Given this list of marker genes PTGES2, CEBPB, PTPN11, MTOR, CAMK2D, CAMK2G, CAMK2A, JAK1, RAPGEF1, PRKCD, CRKL, SMAD7, PIK3CA, STAT1, IL1B, IFNG, IFNGR1, RAP1A, RAP1B, CBL, MAPK1, IRF9, CREBBP, MAPK3 (NCBI Gene Id 5595), SOCS1, EP300, IRF1, MAP3K11, PIK3R1, STAT3, MAP2K1, AKT1, CAMK2B, PTPN2, PIAS1, CASP1, PIAS4, MAP3K1, DAPK1, JAK2, here is a description of the gene set: Human Gene Set: PID_IFNG_PATHWAY species: Homo sapiens from publication Schaefer CF, Anthony K, Krupa S, Buchoff J, Day M, Hannay T, Buetow KH (PMID 18832364) IFN-gamma pathway